The following is a description of a gene set: Human Gene Set: HP_HEPATIC_AMYLOIDOSIS species: Homo sapiens A form of amyloidosis that affects the liver. Hepatic amyloidosis, and this is the list of marker genes: APOA1, TNFRSF1A, SLC7A7, B2M, LYZ